The following is a description of a gene set: studied in species Mus musculus The process whose specific outcome is the progression of a chondrocyte over time, from its commitment to its mature state. Chondrocyte development does not include the steps involved in committing a chondroblast to a chondrocyte fate. Mouse Gene Set: GOBP_CHONDROCYTE_DEVELOPMENT, and this is the list of marker genes: Chst11, Sulf1, Runx2 (runt related transcription factor 2), Sox9, Serpinh1, Bmpr2, Sfrp2, Axin2, Msx2, Fgf18, Comp, Hoxd11, Acan, Smpd3, Galnt3, Smad7, Rflnb, Matn1, Cst5, Shox2, Tgfbr2, Bmpr1b, Col27a1, Hoxa11, Poc1a, Bpnt2, Sulf2, Ext1, Rarg, Ecm1 (NCBI Gene Id 99700), Rflna, Chsy1, Mia3, Col11a1, Mex3c, Pthlh, Eif2ak3